Given this list of marker genes MRAP, SLC12A2, AAAS, NGLY1, GMPPA, MADD, FGF10, SOX10, ELP1, DST, TP63, FGFR2, PIGQ, FGFR3, PAX1, SETBP1, TRAPPC11, CLDN10, here is a description of the gene set: Alacrima species: Homo sapiens Absence of tear secretion. Human Gene Set: HP_ALACRIMA